The following is a description of a gene set: studied in species Mus musculus Any process that modulates the frequency, rate or extent of extracellular matrix organization. Mouse Gene Set: GOBP_REGULATION_OF_EXTRACELLULAR_MATRIX_ORGANIZATION, and this is the list of marker genes: Ddr2, Lama1, Ddr1, Cflar, Smad3, Nid1, Tgfbr3, Tgfb1, Tcf15, Col6a1, Axin2, Slc2a10, Ets1, Efemp2, Cyp2j6, Tgfbr1, Smad4, Abl1, Colgalt1, Ric1, Lamc1, Has2, Prdm5, Pdpn (NCBI Gene Id 14726), Lama2, Clasp1, Dag1, Lamb1, Tnfrsf1b, Fgfr4, Tnfrsf1a, Chadl, Adtrp, Pparg, Antxr1, Bmp2, Fap, Dpp4, Fscn1 (NCBI Gene Id 14086), Meltf, Carmil2, Phldb2, Zfp469, Tie1, Cst3, Il6, Cpb2, Sox9, Tgfb2, Angptl7, Lamb2, Aebp1, Mad2l2, Rgcc, Itgb3, Abl2, Sema5a, Rb1, Phldb1 (pleckstrin homology like domain, family B, member 1), Ier3ip1, Tnxb, Agt, Clasp2, Notch1, Emilin1, Reck, Lemd3